The following is a description of a gene set: The process in which a post-anal tail is generated and organized. A post-anal tail is a muscular region of the body that extends posterior to the anus. The post-anal tail may aid locomotion and balance. Human Gene Set: GOBP_POST_ANAL_TAIL_MORPHOGENESIS studied in species Homo sapiens, and this is the list of marker genes: WNT5A, VANGL2 (VANGL planar cell polarity protein 2), AXIN1, TMED2, TP63, SFRP2, CHST11, PRICKLE1, TCF15, DCHS1, MED12, NPR2, SP5, SCRIB, PALB2, HES7, EPHA2, FZD3, TRAF3IP1, WNT3A, RIPPLY2